Given this list of marker genes PUS7, MDH1, DHPS, AARS1, LRP2, NAA10, IARS2, SOX4, FGFR2, here is a description of the gene set: species: Homo sapiens Skin crease extending from below the inner canthus laterally along the malar process of the maxilla and zygoma. Infra-orbital crease Human Gene Set: HP_INFRA_ORBITAL_CREASE